The following is a description of a gene set: Human Gene Set: REACTOME_AKT_PHOSPHORYLATES_TARGETS_IN_THE_NUCLEUS AKT phosphorylates targets in the nucleus studied in species Homo sapiens, and this is the list of marker genes: AKT1, AKT3, FOXO4 (forkhead box O4), CREB1, AKT2, FOXO1, FOXO6, NR4A1, FOXO3, RPS6KB2